Given this list of marker genes GPI, TALDO1, PGK2 (NCBI Gene Id 5232, phosphoglycerate kinase 2), ALDOA, SLC2A4, TPI1, INS, SLC2A1, HK1, GPT, G6PD, LDHA, PGAM1, PFKP, SLC2A2, PGK1, GAPDH, here is a description of the gene set: Human Gene Set: WP_CORI_CYCLE species: Homo sapiens Cori cycle